Given this list of marker genes EEF2K, FXR2, CYFIP1, FXR1, FMR1, EIF4E, EIF4A3, here is a description of the gene set: Any process that regulates translation occurring at the synapse. studied in species Homo sapiens Human Gene Set: GOBP_REGULATION_OF_TRANSLATION_AT_SYNAPSE